The following is a description of a gene set: species: Homo sapiens Human Gene Set: NABA_CORE_MATRISOME Ensemble of genes encoding core extracellular matrix including ECM glycoproteins, collagens and proteoglycans One hallmark of ECM proteins is their domain-based structure. Exploiting this characteristic, we established a list of diagnostic InterPro domains commonly found in ECM proteins. We know that some of the domains used to select positively for ECM proteins are also found in transmembrane receptors and proteins involved in cell adhesion (growth factor receptors, integrins, etc) that do not belong to the ECM. These families of proteins also display a subset of specific domains and transmembrane domains incompatible with definition as “extracellular matrix” proteins. Therefore, a second step comprised a negative selection using another set of domains and a transmembrane domain prediction. Manual curation of the matrisome lists also allowed us to add a very few known ECM proteins that do not contain any known domains. Protein-centric predictions were then converted to gene-centric lists. Finally, knowledge-based annotation of these gene lists allowed us to define subcategories within the core matrisome; namely, ECM glycoproteins, collagens, and proteoglycans. We also defined separate lists of domains commonly found in 1) ECM-affiliated proteins (proteins that share either some architectural similarities with ECM proteins or that are known to be associated with ECM proteins; 2) ECM regulators: ECM-remodeling enzymes, crosslinkers, proteases, regulators etc.; 3) secreted factors, many of which are known to bind to ECM and others that may. As for the core matrisome list, we also defined lists of domains that excluded mis-assigned proteins from these categories. Using similar bioinformatic pipelines as for the core matrisome, we defined three categories of “matrisome-associated” proteins: ECM-affiliated proteins, ECM regulators, and secreted factors. from publication Naba A, Clauser KR, Hoersch S, Liu H, Carr SA, Hynes RO (PMID 22159717), and this is the list of marker genes: CRIM1, BSPH1, VWF, PODN, EPYC, MFAP5, COL17A1, OTOG, SRPX, CCN4, COL1A1, COL16A1, MFAP2, COL5A3, COL8A2, FGL1, HAPLN2, COL2A1, CILP, BGLAP, LAMA5, COL6A6, COL25A1, COL28A1, MATN1, ZPLD1, ABI3BP (NCBI Gene Id 79859), DPT, LAMA2, CCN5, COL11A1, SPON2, TECTB, COL6A1, OTOL1, IGFBP4, FBN1, NYX, BMPER, PXDNL, TECTA, EFEMP1, AEBP1, HAPLN4, IGFBP7 (NCBI Gene Id 3490), SRGN, COLQ, HMCN1, COL1A2, TNR, SPARC (NCBI Gene Id 6678), COL22A1, COL9A3, SMOC1, NTNG1, MFAP1, COL9A2, GAS6, THBS1 (NCBI Gene Id 7057), ELSPBP1, RSPO3, CCN1, CCN6, SPOCK3, FBN2, IGFBP2, RELN (NCBI Gene Id 5649), PAPLN, THBS3, FBLN7, LAMC2, EDIL3 (NCBI Gene Id 10085), LAMC1, TINAGL1, MATN4, BCAN, COL19A1, CDCP2, LTBP1, COL15A1, FRAS1, VWCE, MGP, TNFAIP6, PRG2 (proteoglycan 2, pro eosinophil major basic protein), EFEMP2, LGI1, NCAN, RSPO4, USH2A, CCN2, NELL2, TNN, SPP1, NID2, COL6A3, MATN2, INTS6L, OGN, FBLN1, COL10A1, COL26A1, SLIT1 (NCBI Gene Id 6585), SPON1, VTN, COL4A4, PODNL1, FBLN5, AGRN (NCBI Gene Id 389836), COL13A1, COL8A1, VWA1, PCOLCE, RSPO1, SLIT3, COL20A1, FGA, COL18A1 (collagen type XVIII alpha 1 chain), SBSPON, CCN3, DCN, HAPLN1, NTN3, COL11A2 (NCBI Gene Id 494120), FGB, INTS14, BGN, GLDN, CHAD, HMCN2, COL6A5, SPOCK1, EMILIN1, FGG, LAMB4, MFGE8, ASPN, DMBT1, ACAN (aggrecan), LAMA3, ECM1, LAMA1, MATN3, RSPO2, AMELY, VWA3A, FN1, MXRA5, LGI2, DMP1, THBS2, SPOCK2, CTHRC1, VWA5B2, TNC, PRELP, MFAP3, VWDE, COL24A1, NELL1, TINAG, VWA7, EMID1, MMRN2, POSTN, TGFBI, EMILIN3, LRG1, COL7A1, NTNG2, OPTC, SVEP1, SRPX2, ZP2, FGL2, COL4A1, COCH, IGSF10, SNED1, ELN, HAPLN3, LGI4, ESM1, ZP3, MMRN1, VWA5A, PXDN, LAMC3, COL3A1, OIT3, DSPP, IGFALS, ZP4, COL21A1, IMPG2, LTBP3, VWA2, NDNF, PCOLCE2, IGFBP1, TSKU, LAMB1, CRELD1, IGFBP6, POMZP3, NID1, VCAN, COL4A2, VWA5B1, TSPEAR, ADIPOQ, THBS4, LAMB3, FBN3, COL12A1, CILP2, AMBN, MEPE, VIT, FNDC1, PRG4, VWA3B, COL4A3, LUM, SLIT2, COL14A1, NPNT (NCBI Gene Id 255743), IGFBP3, ECM2, FNDC7, COL9A1, EYS, MFAP4, CHADL, IBSP, EGFLAM, IMPG1, FBLN2, OMD, COL5A2, ZP1, TNXB, PRG3, CRISPLD1, THSD4, KERA, LTBP2, LGI3, IGFBPL1, NTN1, AMELX, CRISPLD2, FNDC8, EMILIN2, CRELD2, SPARCL1, COL4A5, LAMA4, FMOD, NTN5, COL23A1, HSPG2, COL27A1, COL5A1, COL6A2, LTBP4, ANOS1, SMOC2, SSPOP, COMP, COL4A6, NTN4, IGFBP5, LAMB2, KCP